The following is a description of a gene set: This event has been computationally inferred from an event that has been demonstrated in another species.<p>The inference is based on the homology mapping from PANTHER. Briefly, reactions for which all involved PhysicalEntities (in input, output and catalyst) have a mapped orthologue/paralogue (for complexes at least 75% of components must have a mapping) are inferred to the other species. species: Mus musculus Reactome Pathway: Class C/3 (Metabotropic glutamate/pheromone receptors) electronically inferred by orthology from the curated human pathway part of: GPCR ligand binding, and this is the list of marker genes: Tas2r119, Gprc6a, Tas2r138, Casr, Tas2r107, Gabbr1, Tas1r2, Tas1r3, Tas2r118, Tas2r108, Tas2r135, Tas2r139, Tas2r105 (taste receptor, type 2, member 105), Tas2r126, Tas2r130, Tas2r137, Tas2r144, Tas2r120, Tas2r131, Tas2r121, Tas2r136, Grm4